The following is a description of a gene set: Genes up-regulated in MCF7 cells (breast cancer) engineered to conditionally express a dominant negative form of CLIM2 by a Tet Off system. The nuclear LIM-only protein 4 (LMO4) is upregulated in breast cancer, especially estrogen receptor-negative tumors, and its overexpression in mice leads to hyperplasia and tumor formation. Here, we show that deletion of LMO4 in the mammary glands of mice leads to impaired lobuloalveolar development due to decreased epithelial cell proliferation. With the goal of discovering potential LMO4-target genes, we also developed a conditional expression system in MCF-7 cells for both LMO4 and a dominant negative (DN) form of its co-regulator, cofactor of LIM domains (Clim/Ldb/Nli). We then used DNA microarrays to identify genes responsive to LMO4 and DN-Clim upregulation. One of the genes common to both data sets was bone morphogenic protein 7 (BMP7), whose expression is also significantly correlated with LMO4 transcript levels in a large dataset of human breast cancers, suggesting that BMP7 is a bona fide target gene of LMO4 in breast cancer. Inhibition of BMP7 partially blocks the effects of LMO4 on apoptosis, indicating that BMP7 mediates at least some functions of LMO4. Gene transfer studies show that LMO4 regulates the BMP7 promoter, and chromatin immunoprecipitation studies show that LMO4 and its cofactor Clim2 are recruited to the BMP7 promoter. Furthermore, we demonstrate that HDAC2 recruitment to the BMP7 promoter is inhibited by upregulation of LMO4 and that HDAC2 knockdown upregulates the promoter. These studies suggest a novel mechanism of action for LMO4: LMO4, Clim2 and HDAC2 are part of a transcriptional complex, and increased LMO4 levels can disrupt the complex, leading to decreased HDAC2 recruitment and increased promoter activity. from publication Wang N, Lin KK, Lu Z, Lam KS, Newton R, Xu X, Yu Z, Gill GN, Andersen B (PMID 17452977) studied in species Homo sapiens Human Gene Set: WANG_CLIM2_TARGETS_UP, and this is the list of marker genes: FSCN1, CIRBP, GAREM1, POLH (NCBI Gene Id 5429, DNA polymerase eta), RPL23AP1 (ribosomal protein L23a pseudogene 1), CAV2, ZNF548, CCNG2, COL12A1, GTSE1-DT, DENND1B, DGKZ, ESR1, RBSN, C21orf58, LMAN1, MYB, FBXW2, MCL1, SUMO1P2, CEACAM1, NPR2, KMT5AP1, DDX11, GAS5, KANSL1, MOS, CDK5RAP3, VCF2, GEN1, NRIP1, CDON, SEMA6B, ZCCHC4, NBAS, ARRB2, LRRC37A2, RALGAPA2, CIC, DBNDD2, BMP7, PMS2P3, REPS2, CTCF-DT, CAMK2N2, TP63, IQCK, SLITRK6, MERTK, RIPOR1 (NCBI Gene Id 79567), ETV3, CHTOP, LINC02941, ARIH2, NUDT16L2P, KRIT1, HPS4, MAVS, SEZ6L2, S100A11P1, EED, PTPN12, BMS1P1, ARG2, ARHGAP22, NFATC3, C19orf48P, E2F2, C1QL1, SMC4, NR2F2, KIF5A, FBXO44 (F-box protein 44), BTF3, MTHFD2L, JMJD7-PLA2G4B, KIAA2013, TP53TG3, ENSG00000307187, PPIL2, AGO2, NEAT1, NADSYN1, USP6, NFYB, EXD3, TUBA3C, ARAP1, ERCC6L, AGAP12P, SLC25A40, PARVA, TFDP1, FBXO3-DT, ABI2, KLF8, GUSBP14, CDK3, KLK7, AOPEP, GALNT7-DT, SLC12A9, ALCAM, CASK, CA11, ARID2, CTNNA1, UPK2, GLYCTK-AS1, SIX2, NOP53, ZBTB7A, ABCC3, ITPRID2, RPL10, NAGA, CALR, TP73, SLC24A1, ACRV1, MAP4 (microtubule associated protein 4), NDUFC2, LEPR, DNAJC10, FER1L4, SDR42E1 (NCBI Gene Id 93517), LINC00841, DNAJC22, PAK2, ETNK2, AMY2B, CTDSPL2, MRS2, MET, BPIFA3, LINC01644, PSMC3IP, SLC17A4 (NCBI Gene Id 10050), FGFR1, ZDHHC12-DT, NACA4P, ASTN2, IL6ST-DT, ATXN7L1, SLC26A2, PSMB2, CD109, ATG13, FAM66A, MLH3, LINC01399, GSPT1, LINC00205, CEP170B (NCBI Gene Id 283638), HPS1 (HPS1 biogenesis of lysosomal organelles complex 3 subunit 1), DBP, DIDO1, OTUD3, RANGAP1, ZHX3 (zinc fingers and homeoboxes 3), ZNF783, PELP1, OFD1, PROSER3, TAPBP, PLK4, BANP, SPG7, LDLRAD4, EML3 (EMAP like 3), DPH5-DT, SFPQ, SLC5A3, DR1 (NCBI Gene Id 1810), NEDD8, CPSF1, CD276, CXXC5, TSC22D1-AS1, SDHAP3, ZNF148, NNT, SRSF5, SKIC2, TRIM8, ACACB, PTPRF (protein tyrosine phosphatase receptor type F), SLC52A2, NAXE, MAGI1 (NCBI Gene Id 9223), ARMC6, ATP6V0D2, BCL2L1, FOXP1-IT1, GFM2, COL18A1, PLEKHA3, CDT1, TSHZ2, GNA12 (NCBI Gene Id 654140), DUS2, ADCY1, UQCC1, SPON1, SPDYE1, ZNF93 (NCBI Gene Id 81931), IGFBP5, ZNF607, DDIT4, RAVER2, TNK2, ZNF354B, ZNF160, TMPO, GALNT13, XPO1, LINC02987, KIZ, DUSP6, SCUBE2, POGZ, RBM33, IGSF3, CASP1, ARHGEF39, SCAF4 (SR-related CTD associated factor 4), ECHDC2, PTCD1, AP1AR-DT, ZNF117, TIMP3, ZCCHC8, IGFBP2, SLC35E3, AOC2 (amine oxidase copper containing 2), YPEL3, NEDD1, SDCBP2-AS1, PPP1R26, SGPP1, NISCH, LINC00662, ANKS6, BRF1, CCDC59, ZMYM3, GLUL, BCL11B, TCTN3, CYP1A2, F2RL1, CDC42SE1, ATP6V0D1, OTUD5, CYB561, RTF1, DLG5-AS1, WDR33, CYP2C9, OIP5-AS1, BVES, MUC20-OT1, SKIC8, SERP1, GGA2, TAF1, EID2, ANAPC5, UBXN10, PTMAP4, NBDY, SOCS2, DTX2P1-UPK3BP1-PMS2P11, TGFBRAP1, DTD2